The following is a description of a gene set: studied in species Mus musculus The chemical reactions and pathways resulting in the formation of a ribonucleoside diphosphate, a compound consisting of a nucleobase linked to a ribose sugar esterified with diphosphate on the sugar. Mouse Gene Set: GOBP_RIBONUCLEOSIDE_DIPHOSPHATE_BIOSYNTHETIC_PROCESS, and this is the list of marker genes: Ak3, Guk1, Umps, Ak4, Ak1, Ak9, Cad, Ak2, Dhodh, Cmpk1